The following is a description of a gene set: C57Bl/6 wild-type and STAT6 KO mice were used to study PPARg and IL-4 signaling. Bone marrow of 3 mice per group was isolated and differentiated to macrophages with M-CSF (20 ng/ml). 20 ng/ml IL-4 was used to induce alternative macrophage activation and 1 uM Rosiglitazone (RSG) was used to activate PPARg. From each mouse 4 samples were generated: 1. M-CSF, 2. M-CSF+RSG, 3. IL-4 and 4. IL-4+RSG. All compounds were added throughout the whole differentiation process, and frech media was added every other day. Control cells were treated with vehicle (DMSO:ethanol). After 10 days, RNA was isolated and gene expression profiles were analyzed using Mouse Genome 430 2.0 microarrays from Affymetrix. from publication Szanto A, Balint BL, Nagy ZS, Barta E, Dezso B, Pap A, Szeles L, Poliska S, Oros M, Evans RM, Barak Y, Schwabe J, Nagy L (PMID 21093321) species: Homo sapiens Human Gene Set: GSE25088_IL4_VS_IL4_AND_ROSIGLITAZONE_STIM_MACROPHAGE_DAY10_DN Genes down-regulated in wildtype bone marrow-derived macrophages treated with IL4: control versus rosiglitazone., and this is the list of marker genes: DSTYK, PRKAR2A, ARPC2, NFATC3, SEMA4A, CRIP1, STX12, KLRD1, TRAP1 (TNF receptor associated protein 1), KIF3C, SLC32A1, OSBPL3, EIF4H, ERLIN1, LRRC66, PRELID1, INTS10, SPI1, RENBP, PIGF, NFIX, HEPACAM2, NAAA, CDC5L, AQP9, ITGA1, LYST, ERCC6L, NOL12, RAB40C, TINF2, CCL4, VAPB, CEP128, CSGALNACT1, LCP1, NACAD, CCR6, LSR, DUSP1, BBS12, AKNA, RAB11FIP1, CPQ, MIS18A, RNF150, MBNL2, FGF13, BPIFA1, PAK4 (p21 (RAC1) activated kinase 4), SEPTIN12, CEP250, NFATC2, TMEM50B, ADAM9, RBMS1, DBN1, DNAJC12, SLC1A5, GSTO1, IRAG2, LTB, CISH, KRTAP17-1, VASP, P2RX5, CFL1, GPR132, SCLT1, ATP6V1B2, OCA2, TAX1BP3, RPL39L, ZNF205, DACT1, EXOC3L4, ARHGAP22, NFE2, NCK2, DNAH8, TRIM7 (NCBI Gene Id 81786), MET, CYRIB, FAM217B (NCBI Gene Id 63939), GPX4, MYADM, USP17L2 (NCBI Gene Id 392198), CX3CR1, SPICE1, PLXNB2, ANXA4, TLL2, HOOK2, IL18R1, PLEKHA5, RASGRP3, TMEM238, DEPTOR, HTT, FAM171A1, MAPK12, PTPN13 (protein tyrosine phosphatase non-receptor type 13), THSD4, MINK1, BAZ1A, MDH2, MCM5, USP45, FOXN2, SLC38A2, MDFIC, WNT2, FHOD1, WFDC5, ZFP30 (NCBI Gene Id 400693), CFH, C3orf85, PLEKHF1, LPAR3, PLEKHM1, FEM1C, MYCBP2, AFDN, ST13, KLC3, NHLRC1, TES (NCBI Gene Id 26136), SLC2A8, FAM149A, NDUFAF7, EDEM1, IL1R1, ISLR2, CYB5R3, ARSK, RGS19, CERS5, SF3B2, TRNAU1AP, MTMR6, ST8SIA2, PPFIBP2, TFDP1, GPR26, CYP27A1, IL17B, TLR1, C3orf70, NFAM1, PHLPP1, SLC25A13, IGBP1, CLIP2 (NCBI Gene Id 84805), WDFY2, MYO1F, HEXB, RASSF4, RIN3, IER5, POLE, NRROS, UMAD1 (UBAP1-MVB12-associated (UMA) domain containing 1), DUSP22, METTL15 (methyltransferase 15, mitochondrial 12S rRNA N4-cytidine), GARS1, RFX5, RPS6KA5, GPR88, GDF2, MIER2, SCTR, GPR65, DGKH, TNFRSF4, WDHD1, PYGB, RIC8A, AHSA1, ITGB2, PHC2, PDLIM5, TNFRSF1A, PRAM1, CYSLTR1, SRRM4, RAB30, ARL2BP, TMCO4, FRRS1, EPHX3, IL15, RAB7A, TTC39B, NHSL2, BUB3, SLC20A1, KCNK6, STX2, CCDC38, LRRC42